The following is a description of a gene set: Expression microarray analysis identified over genes regulated during puberty in the mouse mammary gland. Most prominent were genes whose expression increased in parallel with pubertal development and remained high thereafter. Members of the Wnt, transforming growth factor-beta and oestrogen-signalling pathways were significantly overrepresented. Comparison to expression data from CITED1 knockout mice identified a subset of oestrogen-responsive genes displaying altered expression in the absence of CITED1. Included in this subset are stanniocalcin2 (Stc2) and amphiregulin (Areg). Chromatin immunoprecipitation revealed that ERalpha binds to oestrogen response elements in both the Stc2 and Areg genes in the mammary gland during puberty. Additionally, CITED1 and ERalpha localize to the same epithelial cells of the pubertal mammary gland, supporting a role for interaction of these two proteins during normal development. In a human breast cancer data set, expression of Stc2, Areg and CITED1 parallel that of ERalpha. Similar to ERalpha, CITED1 expression correlates with good outcome in breast cancer, implying that potential maintenance of the ERalpha-CITED1 co-regulated signalling pathway in breast tumours can indicate good prognosis. Human Gene Set: MCBRYAN_PUBERTAL_BREAST_5_6WK_UP Genes up-regulated during pubertal mammary gland development between week 5 and 6. studied in species Mus musculus from publication McBryan J, Howlin J, Kenny PA, Shioda T, Martin F (PMID 17486082), and this is the list of marker genes: ELF1, WEE1, PKP2, ST6GALNAC5, NIPSNAP3A, SIAH2, PPP1R8, MUC15, ERAL1, TMEM45B, HAS2, SERPINA3 (serpin family A member 3), GOLPH3, PSIP1, NIPAL2, EZR, EDNRA, CSN1S2AP, PAM, MMP3, FHL1, NET1, CIRBP, RNF2, MLPH, BCHE, OCLN, SFTPB, ACOT1, SPIN1, CISD1, S100A8, ZBTB16, AVL9, CSN2, NFE2L3, BLCAP, SCARA5, STXBP6, IDH1, SLC25A24, SPP1, SFXN1, MYB, RCC1L, LGALS12, CLU, KITLG, GRHL1, CFAP298, DNAJC12, ATP1B1, LSM14B (NCBI Gene Id 51153), ENPP3, PENK, SNRNP27, UBE3A, ARG2, MMD2, SLC15A2, KRT5, TMEM14C, CD8A, BLTP3A, PPP1R3C, HSPA1B, FBLIM1, FXYD3, CYP4V2, PRSS23, ACSF2, ANPEP, ACOT2, SFTPD, TPP2, TCF7, LIPA, TNFRSF21, TPM2, SOX13, SLC44A2, RAD1, CLDN7, PRKAG2, TSPAN17, MBOAT1, PCOLCE2, GALNT7, KLHL2, UNC50, SOCS6, SOCS2, PAWR, EHHADH, MTARC1, PROM2, TJP3, MIS12, RETNLB, TFAP2C, SEH1L, ART3, CCNK, HLA-DQA2, TLCD4, CLDN8, KLF5, DMAC2, PDGFC, RNF149, CSN1S1, RND3 (NCBI Gene Id 390), NDRG1, CEACAM1, KTN1, PFKFB3, PDK4, ERBB3, DSG2, NUP54, KCNK1, TMEM109, TJP2